The following is a description of a gene set: studied in species Mus musculus Mouse Gene Set: chr2H2, and this is the list of marker genes: Gm11450, Sgk2, Mir7003, Tox2 (TOX high mobility group box family member 2), Ptprtos, Gm11451, Mafb, Gm11446, Top1, Emilin3, Ptprt, Gm826, Gm11447, Gm5270, Gm11454, 9130015L21Rik, Gm14222, Lpin3, Gm14243, Mybl2, Plcg1, Gm14221, L3mbtl1, Srsf6, Chd6, Gm25561, 9430021M05Rik, Gm11449, Gm11448, Ift52, Gm11453, Gm11445, Gm22936, Gm14246, Gtsf1l, Gm14228, Gm11452, Zhx3, 4933416E03Rik